Given this list of marker genes S100a8, Slamf1, Tnf, Fut7, Elane, Adam8, Ptn, Ccl2, Rtn4, S100a9, Nlrp3, Gm5849, Itgb2l, Trim55, Ppbp, Ninj1, Alox5, Mdk, Slamf8, Itgam, Ccr6, Itgb2, Ffar2, Cx3cl1, Lbp (NCBI Gene Id 16803), Aoc3, Jam3, Cd24a (NCBI Gene Id 12484), here is a description of the gene set: Mouse Gene Set: GOBP_LEUKOCYTE_MIGRATION_INVOLVED_IN_INFLAMMATORY_RESPONSE The movement of a leukocyte within or between different tissues and organs of the body contributing to an inflammatory response. species: Mus musculus